Given this list of marker genes NPIPB12, SIGLEC17P, RPP40, GPLD1, RHEBL1, RN7SK, ANKRD30BL, XRCC4, GINS3 (GINS complex subunit 3), UBE2E2, ZC2HC1A, RTP4, NBPF15, here is a description of the gene set: Genes up-regulated in T cell 1d vs 0d in adults after exposure to 2011-2012 trivalent inactivated vaccine (A/California/7/09 (H1N1), A/Perth /16/2009 (H3N2), B/Brisbane/60/2008), time point 1D. Comment: Up-regulated DE RNA transcripts (up >= 1.5x) shared between both TIV-vaccinated donors species: Homo sapiens Systems biology is an approach to comprehensively study complex interactions within a biological system. Most published systems vaccinology studies have utilized whole blood or peripheral blood mononuclear cells (PBMC) to monitor the immune response after vaccination. Because human blood is comprised of multiple hematopoietic cell types, the potential for masking responses of under-represented cell populations is increased when analyzing whole blood or PBMC. To investigate the contribution of individual cell types to the immune response after vaccination, we established a rapid and efficient method to purify human T and B cells, natural killer (NK) cells, myeloid dendritic cells (mDC), monocytes, and neutrophils from fresh venous blood. Purified cells were fractionated and processed in a single day. RNA-Seq and quantitative shotgun proteomics were performed to determine expression profiles for each cell type prior to and after inactivated seasonal influenza vaccination. Our results show that transcriptomic and proteomic profiles generated from purified immune cells differ significantly from PBMC. Differential expression analysis for each immune cell type also shows unique transcriptomic and proteomic expression profiles as well as changing biological networks at early time points after vaccination. This cell type-specific information provides a more comprehensive approach to monitor vaccine responses. from publication Hoek KL, Samir P, Howard LM, Niu X, Prasad N, Galassie A, Liu Q, Allos TM, Floyd KA, Guo Y, Shyr Y, Levy SE, Joyce S, Edwards KM, Link AJ (PMID 25706537) Human Gene Set: HOEK_T_CELL_2011_2012_TIV_ADULT_1DY_UP